Given this list of marker genes VEGFB, VEGFC, KIT, VEGFD, PIK3CD, SWAP70, CHGA, CCL11, RAC2, PGF, RIN3, VEGFA, here is a description of the gene set: The movement of a mast cell in response to an external stimulus. Human Gene Set: GOBP_MAST_CELL_CHEMOTAXIS studied in species Homo sapiens